Given this list of marker genes SRPK3, PPP1R27, MMP25, FTCD, EFCAB12, BRICD5, RBFOX3, SPATA31G1, MSLNL, SLC5A10, IL9RP3, DNLZ, CEND1, PDE1B, MROH2A, HSPA6, KLKP1, RN7SL472P, AOC3, MIR4521, here is a description of the gene set: Verteporfin is a porphyrinic photosensitizer clinically used for the photodynamic treatment of age-related macular degeneration. The authors previously tested the efficacy of Verteporfin in endometrial cancer cells and observed cytotoxic and anti-proliferative effects. species: Homo sapiens Human Gene Set: BANG_VERTEPORFIN_ENDOMETRIAL_CANCER_CELLS_DN Tha authors analyzed RNA sequencing data to investigate the comprehensive transcriptomic landscape of Verteporfin treated Type 1 endometrial cancer cell lines, including HEC-1-A and HEC-1-B. from publication Bang LG, Dasari VR, Kim D, Gogoi RP (PMID 30846786)